Given this list of marker genes Slc6a4, Hrh3, Htr2a, Htr2c, Slc6a3, Htr2b, Htr1d, Htr4, Sat1, Htr1a, Htr1b, Hmbs, Amd2, Htr1f, Satl1, Maoa, Htr3a, Amd1, Adrb1 (adrenergic receptor, beta 1), Aldh9a1, here is a description of the gene set: Binding to an amine, a weakly basic organic compound that contains an amino or a substituted amino group. studied in species Mus musculus Mouse Gene Set: GOMF_AMINE_BINDING